The following is a description of a gene set: studied in species Homo sapiens The series of molecular signals mediated by the endoplasmic reticulum membrane stress sensor ATF6 (activating transcription factor 6). Begins with activation of ATF6 in response to endoplasmic reticulum (ER) stress, and ends with regulation of a downstream cellular process, e.g. transcription. Under conditions of endoplasmic reticulum stress, ATF6 translocates to the Golgi where it is processed by proteases to release a cytoplasmic domain (ATF6f), which operates as a transcriptional activator of many genes required to restore folding capacity. Human Gene Set: GOBP_ATF6_MEDIATED_UNFOLDED_PROTEIN_RESPONSE, and this is the list of marker genes: ATF6, CREBZF, ATF6B, HSPA5, DDIT3, WFS1, XBP1, MANF, MBTPS1, MBTPS2